Given this list of marker genes HOXC4, WDCP, TMEM221, CCNB3, NFE2L3, CYP7B1 (NCBI Gene Id 9420), ENTREP2, MTHFSD, SCN4A, TSC22D3, TBL2, SAMD7, IGF2BP1, SLC22A12, TMEM106B, DIO1 (iodothyronine deiodinase 1), FOXS1, RGR, TRIM38, HACD1, PCSK9, LRRC3, NPTX2, GARNL3, ELF5, GLI1, PTPN12, NETO1, DNASE1L2, CASKIN1, PCOLCE, MGP, KCNA2, TTC22, HTRA4, RNF144A, TMC3, TNS4, IL16, CDK10, CAMK1G, FGFRL1, NPFFR1, FAM171A2, ENC1, LATS1, ADCY2, FSCN2, CYTH4, FABP3, SPIC, IYD, FBLL1, GFRAL, CLDN4, NEUROG2, LIPC, SSC4D, MMP7, GLIS1, B2M, SCGN, VTN, CSF1R, MIR204, IL7R, KBTBD8, PSPN, PARP14, IL27, MIR32, PLN, KIFC3, LSMEM2, SLC17A8, RIMS3, PM20D2, BRAT1, RDH16, FBXO41, SLC6A4, SLC45A3, PTPRB, TLL2, CYP2G1P, PLA2G7, SLC19A1, CD96, RGS8, JPH3, MIR665, FADS2, C16orf54, COL6A6, LHFPL4, SPMIP8, ACTRT2, BPIFB2, SLC22A7, IL23R, SPNS1, SVOPL, BMPR1B, DLEU7 (deleted in lymphocytic leukemia 7), DHRS2, INA, CGA, RRN3, SST, NRL, GFRA4, SULF1, RNF32, CD207, ARRDC5, MIR504, GPX2, SYTL5, SFTPC, ITGA10, TEKT2, SLC6A19, HCST, here is a description of the gene set: Human Gene Set: GSE36095_WT_VS_HDAC9_KO_TREG_DN from publication Beier UH, Wang L, Han R, Akimova T, Liu Y, Hancock WW (PMID 22715468) Genes down-regulated in T reg: wildtype versus HDAC9 knockout. species: Homo sapiens Targeting histone/protein deacetylase (HDAC)-6, -9, or Sirtuin-1 (Sirt1) augments the suppressive functions of Foxp3+ T regulatory (Treg) cells, but it is unclear if this involves different mechanisms, such that combined inhibition would be beneficial. We compared the suppressive functions of Tregs from wild-type C57BL/6 mice or mice with global (HDAC6-/-, HDAC9-/-, dual HDAC6/9-/-) or conditional deletion (CD4-Cre or Foxp3-Cre and floxed Sirt1; GSE26425) alone, or after treatment with isoform-selective HDAC inhibitors (HDACi). We found the heat shock response was crucial in mediating the effects of HDAC6, but not Sirt1 inhibition. Furthermore, while HDAC6, HDAC9 and Sirt1 all deacetylate Foxp3, each has diverse effects on Foxp3 transcription, and loss of HDAC9 is associated with stabilization of Stat5 acetylation and its transcriptional activity. Targeting different HDAC can increase Treg function by multiple and additive mechanisms, indicating the therapeutic potential for combinations of HDACi in the management of autoimmunity and alloresponses post-transplant.